The following is a description of a gene set: studied in species Mus musculus Mouse Gene Set: GOBP_REGULATION_OF_CALCIUM_ION_DEPENDENT_EXOCYTOSIS Any process that modulates the frequency, rate or extent of calcium ion-dependent exocytosis., and this is the list of marker genes: Adra2a, Syt2, Syt10, Syt3, Rab3gap1, Doc2a, Cbarp, Scamp5 (secretory carrier membrane protein 5), Vamp2, Syt7, Arf1, Rab3a (RAB3A, member RAS oncogene family), Stxbp3, Kcnb1, Syt1, Rph3a, Stxbp1, Rph3al, Rest, Cacna1i, Syt12, Syt15, Pou5f1, Syt17, Trim9, Cadps, Notch1, Doc2g (NCBI Gene Id 60425), Stx1a, Zp3, Baiap3, Syt11, Atp2a2, Gnai2, Syt4, Cacna1g, Syt9 (synaptotagmin IX), Syt5, Cacna1a, Syt8, Syt13, Hyal3, Syt6 (synaptotagmin VI), Rap1b, Cdk5r2, Cdk5, Cacna1h, P2rx7, Unc13b, Doc2b